Given this list of marker genes RASGRP2, RSAD2, IGF2R, SEMA4A, ENPEP, CMPK2, ACOXL, ABHD15, LEF1, USP53, CARNS1, IKZF1, N4BP2L2, RNF144A, IFIT2, ZZEF1, RFLNB, PKNOX1, IL10, RIGI, MACROH2A1, NXF1, MCTP2, RTP4, TGFBR3, THEMIS, TMIE, FOXP3, SLFN5, MIPOL1, VIPR1, NFATC3, DGKA, PLEKHO1, IL21, AQR, DGKD, GPR171, SATB1, BRD4, DNAH2, IRGM, LYPD6B, SGK1, GRAMD2B, CNGA2, ARID2 (AT-rich interaction domain 2), WNT5B, ARID3B, IFIH1, DUSP6, MFSD4A, DUSP10 (NCBI Gene Id 11221), PDE4B, RTN3, IFIT1B, ITK, RNF213, SOX4, DAW1, GUCY1B1, FGD3, ST8SIA1, TAF15, CCR7, PPP2R5A, TGFBR2, PDLIM4, IL17A, PLEKHD1, GRAP2, AGFG2, GGT1, EMP1, KLHDC2, AGO2, NIPBL, CNN3, ALS2CL, DENND2D, C2orf88, FFAR4, FCGRT, XIST, FHIP2A, IL1RL2, EHD3, S1PR1, ZNF318 (NCBI Gene Id 24149), PRR5L, FILIP1L, PTPRA, CSNK1E, ING1, MMP14, CNGA1, SLC16A5, AMIGO2 (adhesion molecule with Ig like domain 2), PDE3B, MYO3B, ACTN1, SV2C, PARP9, POLE2, FANCD2, CTSE, GPR183, PTGIR, MX2, GUCD1, NIPAL1, SLC19A2, DNAH8, DAPL1, IL4, ZNF354C, CCKAR, RORC, MAU2, KLF13, VDR, SLC35G1, ALPK1, RASSF2, ACBD3, GPD2, LAG3, LPAR3, DSP, CPE, PPP1R14C, AQP3, NFE2L2, SFT2D2, EPAS1, SLAMF6, POU2AF1, SPTAN1, PITPNC1, PHF6, ETS2, ID2, NRP2, CLIC4, FAM20A, CAMKK2, METTL9, ADAM19, TEC, PLEKHA6, SLC20A1, TDRP, LMO4, TIMP2, PTGER3 (prostaglandin E receptor 3), CRYBG3, TCF7, ANGPTL2, PPP2R5C (protein phosphatase 2 regulatory subunit B'gamma), CEP97, RTN4RL1, PLEKHF1, CCL20, UBN1, FAM78A, MYO6, ARL4C, ITGB3, IL18R1, RNASE4, ADD3, TRIM25, EMB, RCBTB2, ENSG00000267882, APBB1IP, IRAG1, TRIB2, PRG4, TRIM34, KIAA0040, IFIT3, TRRAP, EEIG1, KLRD1, FOXP1, SLFN13, ITM2A, RBM39, CPNE1, PPIC, PLAC8, MYB, BCL2L11, MBOAT1, LETM2, PLEKHA2, RPL7, TGFB3, ENC1, here is a description of the gene set: Genes down-regulated in CD8 T cells: naïve versus undergoing deletional tolerance. Human Gene Set: GSE14699_NAIVE_VS_DELETIONAL_TOLERANCE_CD8_TCELL_DN studied in species Homo sapiens from publication Parish IA, Rao S, Smyth GK, Juelich T, Denyer GS, Davey GM, Strasser A, Heath WR (PMID 19204323) Peripheral tolerance induction is critical for the maintenance of self-tolerance and can be mediated by immunoregulatory T cells or by direct induction of T cell anergy or deletion. While the molecular processes underlying anergy have been extensively studied, little is known about the molecular basis for peripheral T cell deletion. Here, we determined the gene expression signature of peripheral CD8+ T cells undergoing deletional tolerance, relative to those undergoing immunogenic priming or lymphopenia-induced proliferation. From these data, we report the first detailed molecular signature of cells undergoing deletion. Consistent with defective cytolysis, these cells exhibited deficiencies in granzyme up-regulation. Furthermore, they showed antigen-driven Bcl-2 down-regulation and early up-regulation of the pro-apoptotic protein Bim, consistent with the requirement of this BH3-only protein for peripheral T cell deletion. Bim up-regulation was paralleled by defective IL-7Ra chain re-expression, suggesting that Bim-dependent death may be triggered by loss of IL-7/IL-7R signaling. Finally, we observed parallels in molecular signatures between deletion and anergy suggesting that these tolerance pathways may not be as molecularly distinct as previously surmised.